The following is a description of a gene set: A developmental defect in which a kidney is located in an abnormal anatomic position. Human Gene Set: HP_ECTOPIC_KIDNEY Ectopic kidney studied in species Homo sapiens, and this is the list of marker genes: MLXIPL, FANCA, LIMK1, EBP, XRCC2, CTU2, PALB2, WAC, TRIM28, XRCC4, GNB2, HOXD13, DACT1, FANCD2, FANCC, RBBP8, FAT4, WNT4, RTTN, SMS, CLIP2, GLI3, KDM6A, PIK3CD, PBX1, RFC2, ADAMTS3, CCBE1, DNAJC30, BAZ1B, LRP4, ZMYM3, TRIP13, SNRPB, PSMD12, REST, CHN1 (NCBI Gene Id 27011), LEMD3, ELN (NCBI Gene Id 2006), ARID1B (NCBI Gene Id 645070), SPECC1L, CDC42BPB, MAFB, DIS3L2, RAD51, SF3B2, GTF2IRD2, VANGL1, NRIP1, ZEB2, METTL27, BUD23, GTF2IRD1, STRA6, GDF6, DYRK1A, SALL4, RPS26, HMGA2, KMT2D, FANCF, GTF2I, KNSTRN, FANCE, FKBP6, NCF1, GDF3, APC (NCBI Gene Id 324), WT1, FUZ, SPINK5 (serine peptidase inhibitor Kazal type 5), JAM3, MEOX1, USP9X, VPS37D, STX1A, RIPK4, DNA2, CCNQ, ZMYM2 (NCBI Gene Id 7750), EIF4H, HNF1B, PUF60, FGFR1, TMEM270, SLX4, DDX6, TBL2, NIPBL, DDX59, GPC3, MNX1 (motor neuron and pancreas homeobox 1), BRCA2, H19, SALL1 (NCBI Gene Id 6299), POU6F2